Given this list of marker genes DSCC1, RFC1, POLA1, POLA2, PRIM2, RFC2, CTC1, ACD, PRIM1, TERF2, TERF2IP, POT1, RFC3, POLD3, TERF1, RFC4, PCNA, TEN1, POLD1, TINF2, CHTF18, STN1, RFC5, CHTF8, POLD2, POLD4, here is a description of the gene set: part of: Telomere C-strand (Lagging Strand) Synthesis species: Homo sapiens Reactome Pathway: Polymerase switching on the C-strand of the telomere After the primers are synthesized on the G-Rich strand, Replication Factor C binds to the 3'-end of the initiator DNA to trigger polymerase switching. The non-processive nature of pol alpha catalytic activity and the tight binding of Replication Factor C to the primer-template junction presumably lead to the turnover of the pol alpha:primase complex. After the Pol alpha-primase primase complex is displaced from the primer, the proliferating cell nuclear antigen (PCNA) binds to form a "sliding clamp" structure. Replication Factor C then dissociates, and DNA polymerase delta binds and catalyzes the processive synthesis of DNA.